The following is a description of a gene set: Abstract of publicaton: CD4/CD8 double-positive (DP) thymocytes express the transcriptional repressor Histone Deacetylase 7 (HDAC7), a class IIa HDAC that is exported from the cell nucleus after T cell receptor (TCR) engagement. Through signal-dependent nuclear export, class IIa HDACs such as HDAC7 mediate signal-dependent changes in gene expression that are important to developmental fate decisions in multiple tissues. We report that HDAC7 is exported from the cell nucleus during positive selection in thymocytes, and regulates genes mediating the coupling between TCR engagement and downstream events that determine cell survival. Thymocytes lacking HDAC7 are inefficiently positively selected due to a severely shortened lifespan and exhibit a truncated repertoire of TCR Jalpha segments. The expression of multiple important mediators and modulators of the response to TCR engagement is altered in HDAC7-deficient thymocytes, resulting in increased tonic MAP kinase activity that contributes to the observed loss of viability. Remarkably, the activity of Protein Kinase D, the kinase that mediates nuclear export of HDAC7 in response to TCR signaling, is also increased in HDAC7-deficient thymocytes, suggesting that HDAC7 nuclear export governs a self-sustaining auto-excitatory loop. These experiments add to the understanding of the life/death decision in thymic T cell development, define a novel function for class IIa HDACs, and point to a novel feed-forward mechanism whereby these molecules regulate their own state and mediate stable developmental transitions. Title of manuscript: Nuclear Export of Histone Deacetylase 7 During Thymic Selection Mediates Immune Self-tolerance. abstract of manuscript: Histone Deacetylase 7 (HDAC7) is a TCR signal-dependent regulator of differentiation that is highly expressed in CD4/CD8 double-positive (DP) thymocytes. Here we examine the effect of blocking TCR-dependent nuclear export of HDAC7 during thymic selection, through expression of a signal-resistant mutant of HDAC7 (HDAC7-delta-P) in thymocytes. We find that HDAC7-delta-P Transgenic thymocytes exhibit a profound block in negative thymic selection, but can still undergo positive selection, resulting in the escape of autoreactive T cells into the periphery. Gene expression profiling reveals a comprehensive suppression of the negative selection-associated gene expression program in DP thymocytes, associated with a defect in the activation of MAP kinase pathways by TCR signals. The consequence of this block in vivo is a lethal autoimmune syndrome involving the exocrine pancreas and other abdominal organs. These experiments establish a novel molecular model of autoimmunity and cast new light on the relationship between thymic selection and immune self-tolerance. Goal of Microarray experiment: We did these experiments to determine how alteration of the function of HDAC7, a site-specific and signal-dependent repressor of transcription, changes gene expression in CD4/CD8 DP thymocytes. species: Homo sapiens from publication Kasler HG, Young BD, Mottet D, Lim HW, Collins AM, Olson EN, Verdin E (PMID 21398603) Genes down-regulated in dobule positive thymocytefrom OT-2 transgenic mice injected with agonist peptide: wildtype versus expressing deltaP form of HDAC7. Human Gene Set: GSE26488_WT_VS_HDAC7_DELTAP_TG_OT2_THYMOCYTE_WITH_PEPTIDE_INJECTION_DN, and this is the list of marker genes: ARPC2, ETHE1, PPP2R3C, FMO1, CSNK1E, AHNAK, ZNF326, COPS3, NASP, TTC27, SMAP2, KRT4, NDUFB5, YBX3, NID2, KCND2 (potassium voltage-gated channel subfamily D member 2), PITHD1, CTDSP2, RDH13, SVIL, GAR1, KCNH1, IFI27, COPZ2, SLC12A7, TSPAN31, HOXA2 (NCBI Gene Id 3199), PRMT1, RPL22, MYO1B, ACSL4, SYTL4 (NCBI Gene Id 94121), ECE1, PLEKHA7, TOM1L1, MAP3K4, SPRR2A, ETS2, ANP32A, PTPRJ, BGN, FBLN2, RXYLT1, PTHLH, TXNRD1, SPEG, SLC46A1, ATF4, PYGB, ANXA7, NICOL1, SLC39A8, CPXM1, HSD17B4, JUN, SYNGR1, AMY2A, ALOX15, ERI2, GSTO1, NTRK3, ZFHX3, IRS2, SAG, CCN2, HGSNAT, ACY1, PLK2, ANXA3, SCG2, HIVEP2, POSTN, KIF16B, PHB1, SLC29A1, CSAD, ARG1, S100A9, RHOQ (NCBI Gene Id 56679), PLD2, SDC4, TSPAN6, EGR2, CMTM3 (NCBI Gene Id 123920), SLC4A7, ALDH2, CSE1L, TPBG, N4BP1, SMO, ETNK1, COMT, SLCO3A1, QSOX1, IGF2, PRDX6, MARK3, KLF3, ASCL1, FERMT2, ACAA2, IER3, TIPARP, EMP1, IGF2R, CLN8, FGF11, TGFBI, LATS2, SRSF6, PMP22 (peripheral myelin protein 22), GBP2, GAS2, HS3ST1, REST, NPR3, PROM1, H19, NIPSNAP2, GNL2, MBD6, ISG15, SLC1A4, TNFRSF21, GAS6, IFNAR2, HEY1, FSTL1 (NCBI Gene Id 65385), CAVIN3, PRSS23, DPP6, DHX9, PTGS1, RALGPS2, KDM5B, THBS1 (NCBI Gene Id 7057), EXT1, CP, COL6A2, IL6ST, UNC119B, CPXM2, ACVR1, CAPRIN2, VSNL1, MORC4, DAG1, GPC4, ATP8A1, TUBB6, DDR1, TXNDC16, CHPT1, FKBP7, TGFB3, HES6, ZC3H11A, PTCD3 (NCBI Gene Id 55037), KCNK1, LYSMD2, RNF4, CDR2L, MOCOS, FXN, FGFR2, AMPD3, EPB41L2, FBL, PBX3, ATP2A3, MAGED2, ERGIC1, CYB5A, NSUN2, SLC38A4, ARL8B, S100A10, SOCS3, MAPK12, CARHSP1, OAT, NAV2, KCTD10, EXOSC7 (NCBI Gene Id 23016), RHPN2, PHF13, AQP4, ADK, NEDD4L, TIAM1, RSU1, PPP2CB, SENP6, KLF2, SLC2A4, PCBP2, FADS1, RGS2, IFIT3